Given this list of marker genes Brpf3, Cbx7 (chromobox 7), Khnyn, Fam89b, Acer2, Hnrnpu, Fcgr1, Myef2, Ldb3, Pklr, Htra3, Psg19, Tnfsf13, Dtna, Cyp2c55, Psg25, Xirp1, Krtap4-2, Slc26a5, St8sia3, Psca, Prss32, Plpp6, Eya1, Iqsec3, Fbxw9, Ptp4a1, Gars1, Sftpa1 (NCBI Gene Id 20387), Phc2, Dagla, Psg22, Atxn1l, Tcte1, Gpr149, Atf6, Trnp1, Gm867, Wars1, Dnajb13, Mbnl3, Me3, Scn4b, Dlg4, Psg17, Marf1, Ttc9, Ezh1, Bptf, St8sia6, Vps25, C2cd2l, Ap1g1 (adaptor protein complex AP-1, gamma 1 subunit), Cyp4v3, Cdk6, Adcyap1r1, Trpc3, Nr6a1, Cd37, Stk35, Grb10, Zmiz1, Fev, Arhgef2, Ppp4c, Tnfsfm13, Wnt1, Atg10, Psg21, Trp53inp2, Krtap4-6, Gria2, Psg26, Cntn4, Hpcal4, Bbln, Sfmbt2, Slco1a5, Xylt2, Cry2, Pmm2, Igf2bp2, Parp11, here is a description of the gene set: Genes predicted to be targets of miRBase v22 microRNA mmu_miR_6993_5p in miRDB v6.0 with MirTarget v4 prediction scores > 80 (high confidence targets). from publication Chen Y, Wang X (PMID 31504780) studied in species Mus musculus Mouse Gene Set: MIR_6993_5P